Given this list of marker genes VWF, F9, F10, F2, TPST2, F8, TPST1, here is a description of the gene set: part of: Defects of Coagulation cascade studied in species Homo sapiens Reactome Pathway: Defective factor VIII causes hemophilia A Hemophilia A is an X‐chromosome‐linked recessive bleeding disorder defined by a qualitative and/or quantitative factor VIII (FVIII, F8) deficiency (Salen P & Babiker HM 2019). Patients affected by the mild form of the disease (FVIII activity 0.05–0.4 IU/mL) suffer from bleedings occurring after trauma or surgery. In severe hemophilia A patients (FVIII activity<0.01 IU/mL) bleedings occur spontaneously, whereas moderate hemophilia A patients (FVIII activity 0.01–0.05 IU/mL present with an intermediate bleeding phenotype (White GC 2nd et al. 2001). In healthy individuals, FVIII is synthesized as an ∼ 300-kDa glycoprotein by hepatocytes, liver sinusoidal endothelial cells, and certain types of endothelial cells (Wion KL et al. 1995; Jacquemin M et al. 2006; Shahani T et al. 2009; Turner NA & Moake JL 2015). The FVIII protein contains a domain sequence A1-A2-B-ap-A3-C1-C2 and circulates as an A1-A2-B:ap-A3-C1-C2 heterodimer bound noncovalently to the von Willebrand factor (vWF) protein. vWF protects FVIII from rapid clearance (Lenting PJ et al. 2007). During the activation of FVIII by thrombin to FVIIIa, the B domain and an activation peptide (ap) are released, and cleavage between the A1 and A2 domains produces an A1:A2:A3-C1-C2 heterotrimer (Lollar P & Parker ET 1991; Nogami K et al. 2005; Newell JL & Fay PJ 2007; 2009). Once activated, FVIIIa dissociates from vWF and binds to the membrane of activated platelets to assemble with activated factor IX (FIXa) (Gilbert GE & Arena AA 1996; Ahmad SS et al. 2003; Panteleev MA et al. 2004; Ngo JC et al. 2008). At physiologic concentrations, the A2 subunit spontaneously dissociates, leading to loss of FVIIIa cofactor activity (Lollar P & Parker CG 1990).<p>Hemophilia A results from a broad spectrum of mutations that occur along the entire length of the F8 gene causing diverse molecular phenotypes that result in similar disease states (Peyvandi F et al. 2016). Together with missense mutations being the most common type of mutations in hemophilia A, a relatively frequent cause is ascribable to nonsense and splice site mutations, deletions/insertions and promoter mutations (Hakeos WH et al. 2002; Wei W et al. 2017; Jacquemin M et al. 2000; Amano K et al. 1998; Gilbert GE et al. 2012; Pahl S et al. 2014; Peyvandi F et al. 2016). In addition, the inversion of intron 1 or 22 in the F8 gene is responsible for approximately half of severely affected hemophilia A patients (Antonarakis SE et al. 1995). Although specific FVIII missense mutations correlate with defects including decreased secretion or stability and specific functional impairment of FVIII, the mechanisms of the majority of missense mutations are poorly understood (Hakeos WH et al. 2002; Wei W et al. 2017, 2018; Jacquemin M et al. 2000; Amano K et al. 1998; Gilbert GE et al. 2012; Pahl S et al. 2014). Defects in FVIII activity may also result in potentially slowing down FVIII activation by thrombin or altering stability of activated FVIIIa.<br><br>